Given this list of marker genes B4GALT1, PRELP, KERA, OMD, LUM, ACAN, FMOD, OGN, here is a description of the gene set: Congenital disorders of glycosylation (CDG, previously called carbohydrate-deficient glycoprotein syndromes, CDGSs), are a group of hereditary multisystem disorders. They are characterized biochemically by hypoglycosylation of glycoproteins, diagnosed by isoelectric focusing (IEF) of serum transferrin. There are two types of CDG, types I and II. Type I CDG has defects in the assembly of lipid-linked oligosaccharides or their transfer onto nascent glycoproteins, whereas type II CDG comprises defects of trimming, elongation, and processing of protein-bound glycans. Clinical symptoms are dominated by severe psychomotor and mental retardation, as well as blood coagulation abnormalities. B4GALT1-CDG (CDG type IId) is a multisystem disease, characterized by dysmorphic features, hydrocephalus, hypotonia and blood clotting abnormalities. part of: Diseases associated with glycosaminoglycan metabolism studied in species Homo sapiens Reactome Pathway: Defective B4GALT1 causes B4GALT1-CDG (CDG-2d)